The following is a description of a gene set: Human Gene Set: GSE17974_0H_VS_4H_IN_VITRO_ACT_CD4_TCELL_DN The aim of this dataset was to study in detail the transcription kinetics initiated by cytokine IL-4 in early differentiation of Th2 cells. from publication Elo LL, Järvenpää H, Tuomela S, Raghav S, Ahlfors H, Laurila K, Gupta B, Lund RJ, Tahvanainen J, Hawkins RD, Oresic M, Lähdesmäki H, Rasool O, Rao KV, Aittokallio T, Lahesmaa R (PMID 20620947) Genes down-regulated in comparison of untreated CD4 T cells at 0 h versus the untreated cells at 4 h. studied in species Homo sapiens, and this is the list of marker genes: COA4, AIMP2, C2orf42, LTA, SCO2, PPAN (peter pan homolog), SLC35F3, PIGM, MRPL12, ABAT, PKNOX1, AK2, PSMB5, BCAT1, SNRNP35, TNFSF11, DDX10, SLC39A14, PNP, IRF8, DNAJB6, PKIA, LINC01128, DNPH1 (2'-deoxynucleoside 5'-phosphate N-hydrolase 1), ATP6V1F, COPB2, MAGED2, MMACHC, TIMM44, ZNF584, KCTD21, GADD45GIP1, DUSP18, ZMYM6 (zinc finger MYM-type containing 6), RRP9, IL2RA, BCL2A1, PDCD2L, ZPR1, SLAMF1, GFOD1, ZNF239, NDUFA8 (NADH:ubiquinone oxidoreductase subunit A8), ZNF607, EGR3, NAB2, RBM28, ZSCAN12P1, PSMG1, MIR3142HG, GEM, NR4A3, CHMP2A, BYSL, USE1, LEO1, NASP, JMJD4, ALKBH2, DESI1, MRPL17, TTI2, MLYCD, MFAP1, PPIL1 (peptidylprolyl isomerase like 1), WDR12, CD200, PALS2, LYSET, PSMD8, ID3, NTMT1, GLB1, PRDX4, IFNA1, SERAC1, GAR1, ANKS3, GEMIN6, NCBP1, GRB10, AARS1, WDR77, CLDN1, FADD, TMEM147, CHAC2, CLEC2D, AEBP1, EIF2S2, UMPS, SNX8, GLMN, ALG1, STARD4, EPOP, CSTF3, GRWD1, MED18, SRM, IFNAR1, FBLN7, LYST, CTSL, IDI2, IL18R1, C11orf24, IRF4, ZNF234, DCTPP1, CBR1, PSMB2, LTBP4, C14orf119, TNF, NUP42, TTLL4, C3orf52, DPAGT1, MIR17HG, POGLUT1, IPO4, BTBD19, TP53BP1, CDK4, MRPS16, BTLA, TRDMT1, ACSL4, TNFSF14, FKBP2, UBE2NL, ELP5, POU2AF1, LYAR, UTP11, NDFIP2, WIZ, DHRS7B (dehydrogenase/reductase 7B), DSE, EGR2, CISH (cytokine inducible SH2 containing protein), GFI1, ZNF232, ZNF443, NT5E, SH2D2A, POLD2, SPATA31C2, POP1, COPRS, EIF2B2, CCDC86 (NCBI Gene Id 79080), S1PR2, GON7, CMSS1, HAX1, POLR2F, PEAK1, NUDCD1, FTSJ3, ALG3, NUBP1, PRMT1, ZNF165, STIP1, TNS3, EOMES, SF3B3, PRELID1, MIR155HG, ZNF322, PNO1, CNOT1, PPP1R14B, POLR3D, ZNF71, TACR3, MRPL18, RRS1, PRPF38A, TNFRSF4, NAGK, PRDX1, CCL20, HCP5, MOB3C, RRP1, ARL13B, MRRF, FASLG, EIF2B4, PACC1, BAZ1B, ASNS, SLC35A5, C1GALT1C1, MRPS7, RNF34